Given this list of marker genes SHH, EDA, TGM2, EDAR, NFIB, here is a description of the gene set: The formation of a lumen by hollowing out a solid rod or cord. Human Gene Set: GOBP_TUBE_LUMEN_CAVITATION studied in species Homo sapiens